Given this list of marker genes Dtx2, Ubb, Dtx1, Dtx4, Rps27a, here is a description of the gene set: electronically inferred by orthology from the curated human pathway studied in species Mus musculus This event has been computationally inferred from an event that has been demonstrated in another species.<p>The inference is based on the homology mapping from PANTHER. Briefly, reactions for which all involved PhysicalEntities (in input, output and catalyst) have a mapped orthologue/paralogue (for complexes at least 75% of components must have a mapping) are inferred to the other species. part of: Signaling by NOTCH1 Reactome Pathway: Activated NOTCH1 Transmits Signal to the Nucleus